Given this list of marker genes CHRNA2, GABBR1, GPR158, P2RY11, GRIK3, CHRNA9, HRH4, GLRB, GABRR2, GABRG2, CHRNB3, GABRA3, LYPD6B, CHRNA6, HTR3A, LYPD6 (LY6/PLAUR domain containing 6), CHRM3, DRD4, PATE1 (NCBI Gene Id 160065), LY6H, HTR3B, CHRNE, HTR4, GABRB1 (NCBI Gene Id 2560), GABRR3, HTR6, HTR1B, GRIN3A, GRID1, HTR3C, HTR7, GRM5, TSPO, GRIN3B, HTR3E, GRIA4, HTR1D, DRD2, HTR5A, GLRA3, DRD1, GABRG3, DRD3, CHRM2, LY6E, GABRQ, GRIK2, GRIN2C, GRIN2B, GRM1, GABRA4, GRIK4, GABRG1, GABRA1, ADRB1, GABRR1, CHRNB2, HTR1E, GABRE, TMEM35A, LYNX1, GABRD, CHRNA4, ANXA9, HRH3, KCTD16, GABRA5, CHRNB4, CDK5, GLRA1, CHRNA10, GRIN2D, GLRA2, HTR3D, CHRNA1, PTK2B, HTR1A, GABRA2, GRIA1, SPDYE11, GRIK1, GRIN2A, HTR1F, GRIA2, GABRB2, CHRND, CHRNA3, HTR2C, CHRM1, GABRP, GRIK5, HRH2, HTR2B, GABRA6, HTR2A, CHRM4, GRID2, SLURP1, LYPD1, PATE4, CHRFAM7A, GABRB3, CHRNG, PSCA, SLURP2, LY6G6D, GRIA3, GRIN1, APP, CHRNA5, CHRNB1, CHRM5, CHRNA7, LY6S, DRD5, here is a description of the gene set: Combining with a neurotransmitter and transmitting the signal to initiate a change in cell activity. Human Gene Set: GOMF_NEUROTRANSMITTER_RECEPTOR_ACTIVITY species: Homo sapiens